Given this list of marker genes RPL19 (ribosomal protein L19), PER1, NCKIPSD (NCBI Gene Id 51517), LONRF3, GIT1, BATF3, CGN, TAF6L, PCDHA10, BAX, HNRNPD, KAT6A, WASHC4, ACACA, GLA, IQGAP2, WDR20, GTF2H1, PDP2, GYG1, COMMD3, CLN3, GADD45G, WEE1 (NCBI Gene Id 7465), RHOQ, WIPI1, EIF4E, SEPTIN3, STMN1, SNTB2, NEUROD2, C4B, SYT3, TRIM46, ZKSCAN7, IGF2R, NDUFS1, PRPF38B, GNA13, ATXN7L1, TAC1, NEUROD1, IRS4, MRPL27, IER5L, IPO7, ILF3, HOXC11, TMEM108, HOXC5, ARL3, ELK1, DNMT3A, ATP6V1H, ETV1, GNB2, EFTUD2 (elongation factor Tu GTP binding domain containing 2), SCHIP1, GLYR1, RAPGEF3, PTMA, EN1, SLC25A33, RPS2, NRAS, LSR, CNOT4 (NCBI Gene Id 4850), PKN1 (protein kinase N1), UBXN10, HOXB6, SLC1A7, LTBR, ARHGAP45, YBX1, C1orf43 (chromosome 1 open reading frame 43), EIF4G1, NPM1, SYT13, HOXA9 (homeobox A9), HOXA3, KICS2, ARTN, MAX, HMOX1, TLL1, EWSR1, PCED1A, SC5D, MRM1, NFX1, RASSF7, FLVCR2, KLF4, PHF20, AKAP12 (NCBI Gene Id 9614), SIRT1, SPNS1, MINK1, CHD4, HMGN2, STARD13, RGL2 (NCBI Gene Id 9264), CDH1, GK, HNRNPH2, TMED10, PANK3, USPL1, PFDN2, VLDLR, SNN, SGK1, ZNF318, SSR1, ARMT1, RNF115, HOXA7, BDNF, SRCIN1, COPS7A, AATF, ADAM10, FGF14, TRMO, UBE2B, CCAR1, JUP, HOXD10, KBTBD2, VPS37B (NCBI Gene Id 79720), TGIF2, SLC16A1, SFXN2, CUTA, MFHAS1 (multifunctional ROCO family signaling regulator 1), TFAP4 (transcription factor AP-4), APLN, CSRNP1 (NCBI Gene Id 64651), KRTCAP2, RAB3IL1, NTN3, EIF5A, LAMP1, BATF2, WFIKKN2 (WAP, follistatin/kazal, immunoglobulin, kunitz and netrin domain containing 2, NCBI Gene Id 124857), CLUH, IGF2BP1, RAMP2, VPS16, HOOK2, TMEM47, STX6, HSPA9, KCNE4, GPR157, AGRP, SOCS5, TCP11L2, DUSP7 (dual specificity phosphatase 7), FGF5, TCF7 (NCBI Gene Id 6932), HPS5 (HPS5 biogenesis of lysosomal organelles complex 2 subunit 2), ILF3-DT, DCAF11, EEF1B2, LMNTD2, DCTN4, DCAF13, TRIB1, GTF2A1, KCTD15, ZFX, HIF1A, MKS1, HRH3, KAT14, HEXA, DOLK, NR3C2, METAP1D, TRMT2A, ELOVL3, ATP7B, EPB41L4B, RANBP1 (RAN binding protein 1), SMYD4, BHLHE41, HOXB7, WBP2, HNRNPH3, TMEM132E, RLIM, POGK, CCNYL1, RPUSD4, EGLN2, SLC43A1, ANKRD12, ACAP3, HOXA1, HOXC12, LIN28A, LRRN4CL, APEX1, ABR, RAB31, PICALM (phosphatidylinositol binding clathrin assembly protein), SERBP1 (SERPINE1 mRNA binding protein 1), IGSF22, ATF7IP, TET2, ANKRD17, FAM13B, SPIB, SLC31A2, ADNP2, KLHL28, TADA1, UTP14C, DIAPH1, DYM, CREBRF, HNRNPDL, ABHD17B, DRICH1, PPM1A, TMEM150A, SLC26A2, NPTX1, TFAP2C, STC2, ZBTB40, VGF, MCOLN1, GNAS, EIF3B, HPGD, MPV17, TOGARAM1, STT3B, LZTS2, RNF44, WDR1, NR5A1, here is a description of the gene set: Genes having at least one occurrence of the motif NRCCACGTGASN in the regions spanning 4 kb centered on their transcription starting sites. This matches the transcription factor binding site V$USF_Q6_01 (v7.4 TRANSFAC). species: Homo sapiens Human Gene Set: USF_Q6_01